The following is a description of a gene set: Interaction of hematopoietic progenitors with the thymic stromal microenvironment induces them to proliferate, adopt the T cell fate, and asymmetrically diverge into multiple T lineages. Progenitors at various developmental stages are stratified among different regions of the thymus, implying that the corresponding microenvironments differ from one another, and provide unique sets of signals to progenitors migrating between them. The nature of these differences remains undefined. Here we use novel physical and computational approaches to characterize these stromal subregions, distinguishing gene expression in microdissected tissues from that of their lymphoid constituents. Using this approach, we comprehensively map gene expression in functionally distinct stromal microenvironments, and identify clusters of genes that define each region. Quite unexpectedly, we find that the central cortex lacks distinctive features of its own, and instead appears to function by sequestering unique microenvironments found at the cortical extremities, and modulating the relative proximity of progenitors moving between them. species: Homo sapiens Human Gene Set: GSE18281_CORTICAL_VS_MEDULLARY_THYMOCYTE_DN Genes down-regulated in thymocytes: cortical versus medullary sources. from publication Griffith AV, Fallahi M, Nakase H, Gosink M, Young B, Petrie HT (PMID 20064453), and this is the list of marker genes: SAT1, ACAT2, ACOT9, RARS2 (NCBI Gene Id 91066), SLC30A3, MRPL33, BLK, MMP11, RASL12, CMAS, TRAT1, NDUFA6, PCDHB17P, SLC34A1, MIA2, PRRG3, GRIK1, SCTR, PWAR5, NOS2, GNG13, FNDC3B, RAMP3, GRIA2, ZBTB32, GP9, DDN, ACADM, SAA4, ZNF770, UQCR10, ACTL7B, MED4, CUZD1, CXCR1, SVEP1, SYN3, COLEC10, APCS, GSTM5, VN1R1, PNMT, TACR3, IMPA1, CYCS, HRK, IDI2-AS1, EN1, POLR1F, GALR2, PTPRJ, GTPBP10, VIP, ERBB4, EML2 (NCBI Gene Id 24139), ZNF287, CRYM (NCBI Gene Id 1428), CDX4, OR12D2, A1CF, KIR3DX1, TNFSF12 (TNF superfamily member 12), ADAM12, ANKRD40, RBM12B, SAR1B, SPRY4, SERPINI1, LMX1B, ANKS1B, AK5, CHCHD3, TARP, MYH7B, TRIM15, PRB3, IL36G (NCBI Gene Id 56300), TCF21, MSC, HCCS, HNF4A, SLC8A2, ACKR1, NOMO3, ZIC3, MRPL41, POM121L2, SLC4A1, GCA, ATF1, PIP, PYY2, TMOD1, TYRP1, CETN3, SEMA6B, MFAP5, RAB4B, ASTN1, GAPDHS, ATP5PB, PEX6, SSTR1, NTSR1, EXOC6B, ISG20, DNAJA4, BMP8B, SDCBP, PRDM13, PCBP3, XRCC4, CHMP4A, MTHFD2L, PIK3R5, PAX5, MMP17 (matrix metallopeptidase 17), RAMP2, SERINC2, PLP1, ZFYVE16, GJA4, BMP8A, HAL, C6orf15, SLC11A2, ASL, TG, HAPLN1, HAND2-AS1, SH2D2A, DOCK2, PSG4, PSMD10, CSF2RB, DDT, ADAMTS6, ASH1L, SPTSSA (NCBI Gene Id 171546), NDUFAF4, QPCTL, MYCNOS, IL10 (NCBI Gene Id 3586), EPHB1, IGLV4-60, HOXA11, TNFAIP6, S100G, CTBS, RWDD3, GBX1, DEFB4A, LHCGR, CDK5R2, SNAP25, JAK3, CYP11B1, MAFF (MAF bZIP transcription factor F), SLC43A1, PIGH, SLC66A1, ERN1, BIN2, GKN1, CASP10, CCR7, SDHD, AMPD1 (adenosine monophosphate deaminase 1), PROM1, RALYL, PSPN, PHF20, CSF3R, ARNT2, GDF10, FOLR3, SPRR2B, BMP5, AEBP1, DIO3, SLC17A2, GAS8-AS1, TTPA, IER3IP1, MYL3, DPEP3, G6PC1, ENTPD1, BMP15, ZC3H12A, CLUL1, LINC00939, WIPF1, TAC3, CLDN17, OR1E1, GPA33